The following is a description of a gene set: Sensory processing of sound Human Gene Set: REACTOME_SENSORY_PROCESSING_OF_SOUND species: Homo sapiens, and this is the list of marker genes: RAB3A, ACTG1, SLC26A5 (NCBI Gene Id 80269), CAPZA2, LRRC52, BSN, LHFPL5, TMC1, SLC17A8 (NCBI Gene Id 64944), PLS1, MYO7A, MPP1, GRXCR1, MSN, STX1A, SNAP25, CAPZA1, USH1G, ESPNL, FSCN2, ACTB, PJVK, CIB2, TWF2, CHRNA9, RDX, XIRP2, EPB41L1, TMIE, EPS8, KCNMA1, PCDH15, KCNMB1, STRC, OTOF, CASK, MYH9, ATP2B2, KCNQ4, GRXCR2, RIPOR2 (NCBI Gene Id 9750), OTOGL, EPB41L3, WHRN, MYO3A, CLIC5, CHRNA10, KCNN2, CABP1, TPRN, ATP2B1, MYO1C, VAMP2, EPS8L2, MYO3B, USH1C, SYP, CDH23, OTOG, CABP2, SYN1, CTBP2, PCLO, TRIOBP, CACNB2, CACNA1D, EZR, MYO15A, SPTBN1, GSN, ESPN, CACNA2D2, TMC2, CAPZB, TWF1, DNAJC5, SPTAN1